The following is a description of a gene set: studied in species Homo sapiens Recurrent pneumonia An increased susceptibility to pneumonia as manifested by a history of recurrent episodes of pneumonia. Human Gene Set: HP_RECURRENT_PNEUMONIA, and this is the list of marker genes: B3GALT6, STK4, SLC35C1 (solute carrier family 35 member C1), GNPTAB, MRAP, CFAP410, FCHO1, CARMIL2, PKP1, WAS, CYBA, CCDC39, RNF125 (ring finger protein 125), FBXW7, IL2RG, RFXAP, RNU4ATAC, COL11A2, FCGR2A, TGFB1, ADA, SETBP1, ZBTB7A, IDS, SFTPC, MEGF10, IGBP1, GAS8, CLXN, DNAH11, NME5, USB1, DDR2 (NCBI Gene Id 4921), EGFR, LTBP1, C3, LRBA, RFXANK, UNC119, CD3E, RNU4-2, PGM3, ERCC6, CYBB, DOCK8, TNFRSF13B, PURA, TK2, MED25, AASS, C4B, NBN, PIK3CD, NKX2-1, NCF1, PLOD1, AP3B1, ORC6, TBX1, CD19, ZNF341, CEBPE, IGKC, IL6ST, USP26, NCF2, DNAAF4, TNFRSF13C, CFTR, LEP, RAC1 (Rac family small GTPase 1), IDH1 (NCBI Gene Id 3417), CR2, SREBF1, DRC1, TCF3, CCDC40, RNF168, RFX5, JAK3, FBLN5, TONSL, RFX7, PEPD, GALNS, IL21R, DOCK11, LAT, EFEMP2, CD247, ODAD4, IGHM, BTK, PKHD1, DOCK2, SERPINH1, NFKB2, RAC2, ODAD2, WDR19, POLA1, CD27 (NCBI Gene Id 939), SIAH1, HYDIN, CYBC1, CD79B, SMARCA2 (NCBI Gene Id 95083), CD3D, MASP2, EXTL3, BLNK, CLPB, ICOS, ALMS1, DZIP1L, WDR35, KCNJ6, IGHG2, SMARCD2, ALG12, FMO3, TBCD, TNFRSF11A, P4HTM, KPTN, ZNFX1, MTHFD1, LTBP4, STIM1, VPS33A, IFIH1, STK36, RELB, STAT3, CAVIN1, NFKB1, LMNB1, ARPC1B, CXCR4, ODAD1 (NCBI Gene Id 93233), WDR1, IGLL1